The following is a description of a gene set: species: Mus musculus The chemical reactions and pathways involving amyloid precursor protein (APP), the precursor of amyloid-beta, a glycoprotein associated with Alzheimer's disease. Mouse Gene Set: GOBP_AMYLOID_PRECURSOR_PROTEIN_METABOLIC_PROCESS, and this is the list of marker genes: Psen2, Tmed10-ps, Hap1, Bace2, Itm2a, Ago2, Abca2, Sp1, Ranbp9, Dyrk1a, Abcg1, Itm2c, Chrna7, Efna3, Adam10, Adam9, Apoe, Necab3, Psenen, Casp3, Flot2, Lrrtm3, Aph1c, Slc2a13, Psen1, Rtn2, Rtn1, Igf1, Dlg1, Ifngr1, Pin1, Soat1, Picalm, App, Tmcc2, Aph1a, Tmed10, Bace1, Clu, Rps23rg1, Necab2 (NCBI Gene Id 117148), Ntrk2, Rela (NCBI Gene Id 19697), Csnk1e, Dhcr24, Rtn4, Prnp, Gga3, Cln3, Aatf, Bin1, Unc13a, Pawr, Spon1, Aph1b, Ifng, Ldlrap1, Adam17, Gsap, Naglu, Ager, Pin1rt1, Nsg1, Sorl1, Ncstn, Rtn3, Itm2b, Lyn, Abca7 (NCBI Gene Id 27403), Rock1, Epha4, Gsk3a, Adam19, Necab1, Efna1, Rock2, Tnf